Given this list of marker genes KIR3DL1, IDH3A, DCTN5, NOG, CAV3, IGFBP3 (NCBI Gene Id 3486, insulin like growth factor binding protein 3), CDK5R1 (cyclin dependent kinase 5 regulatory subunit 1), PRRC2C, here is a description of the gene set: Human Gene Set: MIR4671_5P studied in species Homo sapiens from publication Chen Y, Wang X (PMID 31504780) Genes predicted to be targets of miRBase v22 microRNA hsa-miR-4671-5p in miRDB v6.0 with MirTarget v4 prediction scores > 80 (high confidence targets).